The following is a description of a gene set: Mouse Gene Set: GOCC_MITOCHONDRIA_ASSOCIATED_ENDOPLASMIC_RETICULUM_MEMBRANE_CONTACT_SITE A zone of apposition between endoplasmic-reticulum and mitochondrial membranes, structured by bridging complexes. These contact sites are thought to facilitate inter-organelle calcium and phospholipid exchange. studied in species Mus musculus, and this is the list of marker genes: Stx17, Bcap31, Clcc1, Mboat7, Tmx2, Serac1, Tomm20, Vps13a, Pdzd8, Tomm40, Atg5, Canx, Bcl2l10, Fate1, Zfyve1, Atg14, Acsl4, Atad3a, Rab32, Tmx1, Ahcyl1, Tmem41b (transmembrane protein 41B), Selenon, Rab38